The following is a description of a gene set: from publication Yevshin I, Sharipov R, Kolmykov S, Kondrakhin Y, Kolpakov F (PMID 30445619) Human Gene Set: UBN1_TARGET_GENES Genes containing one or more binding sites for (UBN1) in their promoter regions (TSS -1000,+100 bp) as identified by GTRD version 20.06 ChIP-seq harmonization. studied in species Homo sapiens, and this is the list of marker genes: WIZ, GANC, ZNF30-AS1, HMOX2, ZBTB26, TNPO1, FAM217B (family with sequence similarity 217 member B), MIA2, NME1, TANC1, CCDC127, RAPGEF2, LINC02980, PSME2, CKS1B, ZBTB7C, STRC, CENPS-CORT, AHCYL1, POLR1H (NCBI Gene Id 30834), PIBF1, ZNF839, COX5B, CT70, H4C8, DBF4 (NCBI Gene Id 10926), PCBP2, MRPL50, RANBP3L, ZBBX, LNCTSI, KDM1A, PMS2P3, SLC22A4, CARD8, TOP1, ABL1, GFOD1, TMEM91, SMARCC1, PSMD1, NNMT, BCAP29, MIA2-AS1, SLC24A1, CTNNA1-AS1, NREP, PPM1D, SELENOM, HNRNPU, LRRC51, MIR181A2HG, INTS11, USP13, EIF2A, ATXN7L1, CPEB2-DT, VPS35L, ACIN1, TNFRSF19, BASP1-AS1, DNAJC13, ABHD10, NOC3L, UBE2V1, MAP3K7, LHX2, VPS26C, MRPS35-DT (NCBI Gene Id 107984461), PIK3CA, PTK2, GABARAPL1, PPP2R5A, DLST, NOSTRIN, PMS2P4, SARS1, RAI14, ZC3H13, CCT4, RNF212, GOLGA7, COX4I1, B3GALNT2 (beta-1,3-N-acetylgalactosaminyltransferase 2), NIP7, AURKB, CDA, RALGAPA1, LDHA, IVNS1ABP, CARNMT1, LZIC, EHF, C6orf62, KDM2A (NCBI Gene Id 22992), PTDSS1, RIMS1, AP1AR-DT, NPLOC4, NDFIP2, NTAN1, PPP3CB, KRIT1, LINC02958, ANKRD11, PTPN12, ERI2, WDR31, ANO6, SRSF8, ANKIB1, RABGAP1L-DT, KIF2C, RPSA, SUPT16H, ATP5MK, RERE, TTC39C, LMO4, VTA1, RND2, UBB, MRPL55, SYT11, EIF2B4, PANK3, IER2, POLH, BARD1, NUP43, H2AZ1-DT, SNX3, PRC1, TRIM45, GADD45GIP1 (NCBI Gene Id 90480), FTL, MAN1B1-DT, PPP2CB, MATR3, EDEM2, ST7, CARS2, EIF2B5, ANXA11, ASB6, CLIC4, SDSL, SGK1, HSD11B1L, IL6ST-DT, RDH10, XPO5, PPP1R12A, MBIP, COX14, ZNF35, SAR1B (secretion associated Ras related GTPase 1B), MYH9-DT, PTBP1, PSMD14-DT, EPC1, RSPH3, CPEB2 (cytoplasmic polyadenylation element binding protein 2), EEF1A1P23, SYNM, NSA2, PPIP5K2, EPS8, CETN3, GEMIN6, NBPF11, KIAA0930, CD2BP2, DCTPP1, GAREM1, MIR4466, KIAA0825, MICOS13, MSANTD3 (Myb/SANT DNA binding domain containing 3), TRAF4, CMTR2, MED18, CDC25C, YBX3, C1orf43, ZNF112, PHIP, GNG12, NFYC-AS1, NRM, IL18, LINC02615, GPX8, USP33, SHC1, ALG6, RUVBL2, MIR6853, BLOC1S5, ANKRD13D, RRP15, ARID3B, MT1X, RN7SL299P, GGPS1, MYH9, RSRP1, WDR70, LBHD1, NARS2, HCG25, ATG101, H2AC11, SLC27A5, MRPS28 (mitochondrial ribosomal protein S28), SUGT1P4, TBP, SCN9A, GALNT10, SLC38A2, GLS (NCBI Gene Id 51679), VMP1, C6orf47, RNU4-2, P4HA1, G6PD, SPRED1, PPP1R11, CREB3, HIGD1A, ARMH1, DHPS, CYP1B1, ETFBKMT (electron transfer flavoprotein subunit beta lysine methyltransferase), KLHL26, EIF1AX, PCF11, STAMBPL1, GLT8D1, NBPF1, PDLIM7, EPRS1, RASSF1-AS1, KHDRBS1, BSG-AS1, SDE2, LINC01828, SNAPIN, RIPK2, FAM200B, NIPAL3, SBNO2, RNU6-1327P, FOCAD-AS1, DUBR, SNAPC4, SPINK6, MGME1, SNORA16A, IL1RAP, RASSF1, HMGB2, ZNF225, STRAP, SMARCD2, SSB, RNF34, LRRC37A3, FRG1, UBR5, KLRK1, RSBN1, ZNF517, NAA15, BNIP1, PCNX4, THYN1, RN7SL525P, ANXA2, ATL2, MRPS35, CAAP1, DTWD1 (NCBI Gene Id 56986), ZNF787, FAM227B, TRIM4, KHNYN, STAT3 (signal transducer and activator of transcription 3), CCDC88A, RNU6-1276P, DUXAP11, LINC02331, RPS11, UBE2D3-AS1, XYLB, WBP2, DHX38, ADAMTSL4-AS1, OPA1, UPK2, ZNF764, OTUD3, MCTP1, AKIP1, MYLK-AS1, TUBD1, FZD6, RPL27, STAT1, JRKL, SLC30A4-AS1, DROSHA, LINC00881, POLR2K, MIR22HG, CLDN12, GTF2H4, AHCY, NAMPT, SDHA, ZC3H7A, SART1, ADGRG1, SUN1, TRIM5, MAP2K7, TGFBR1, PKM, ZFYVE1, TMEM209, DNAJC3, ABCC3, SKIC8, C12orf60, MIR762HG, ZNF217, MIS18BP1, FAM229B, SIRT1, BTD, AFAP1, GARNL3, CLNS1A, ZBTB17, CLTC, TIPRL, TMEM33, P4HA2, ZMYM6 (NCBI Gene Id 9204), MAN2A2, HECTD1, HMGB1, RDUR, SERINC3 (serine incorporator 3), DNAJC25, HINT1, RAB27A, UBE2R2, ELL, BMF, BICRAL, ENSG00000266401, TNFAIP1, MT1E, SEPSECS-AS1, CXXC5, STAG3L5P-PVRIG2P-PILRB, TMX1, ENSG00000263280, TUBB3, H2BC6, C1QTNF1-AS1, TADA1, NSUN3, ADM-DT, CDKL5, ANP32E, NAGA, TMED7, CCDC82, FHAD1, SCAT8, TXNDC9, LINC02223, MAN1B1, ETV1, ATP6V0A1, PBLD, MAPK4, PITPNM1, FANCM, TLR6, ELMOD2, VPS13B, LRRC27, RNASE11, BRWD3, MRPL33, SYBU, CLIP1, MDC1, VPS13B-DT, PSMA2, MAPK8IP3, VARS2, YIPF3, PA2G4, PLSCR1, RELL1, WDR37, FIRRE, GUSBP1, RB1CC1, SLC38A2-AS1, TGFB1, ATP13A4, H2AC25, RTN2, ZBED6, SLC39A8, IKBKG (inhibitor of nuclear factor kappa B kinase regulatory subunit gamma), LINC01560, RAG1 (NCBI Gene Id 5896), PIK3R3, ZZZ3, CTNNA1, LRRC58, SPTAN1, ZNF862, RNVU1-30, STARD9, CSAD, DNAJC27-AS1, FAM76A, C19orf48P, MAGEF1, LSM5 (LSM5 homolog, U6 small nuclear RNA and mRNA degradation associated), FAM174B, TLN1, AUTS2, KIAA1586, CAV1, TP53BP2, MRPL18, RPS26P29, ANKAR, KIN, PNRC1, SRBD1, SMAD7, COMMD9, ZNF696, SEC24A, AKAP6, PSMA1, GEMIN2, EXOSC6, SIK2, NUMA1, SCN1A-AS1, ZBTB43, FBXO22, KLHL21, USP8 (ubiquitin specific peptidase 8), TCEANC2, RABGAP1L, SH3GLB2, GPC5, MORC3, MRPL45, PCMT1, FEN1, DNAJC25-GNG10, CTSS, PLEKHA3, ZNF548, H2BC10, TNFRSF11B, IL1R1, MYO1G (NCBI Gene Id 64005), THAP1, ATP2C1, MXI1, SRP54, PPIL3, RPS6KB1, POLR1C, ZNF143 (zinc finger protein 143), RACK1, FHIP1A, COX7A2, CHD2, DEPDC1, FUBP1, PDE7B, TAOK2, SNRPA1, SMARCD1, ZNF527, ZNF451, PEX3, H2BC11, TRAJ28, TMEM258, SF3A3, PDK4-AS1, PAK1, RNF168, TXNL4B, GALM, AP3B1, TRIM28, DPAGT1 (NCBI Gene Id 1799), ILF2, CD46, TMED7-TICAM2, HYKK, GAB1, HOXC-AS3, USP3-AS1, GON4L, ACTN3, SNORD104, SINHCAF, PCNX4-DT, ZNF250, ACOT13, LARP1B, IGFBP7, THOC5, DBNL, SAMD4B, PFN1, COG8, NUDT3, ALDH7A1, KCTD3, RAB5B, TMEM263, DENND2B, TOMM34, DAPP1, NDFIP2-AS1, WNT5A, MYORG, CREB3L2-AS1, PARAIL, BAG1, ASB3, CCNH, RPA3, CEP152, GBA1, CISD3, FAS, PGP, MIR759, ZNF225-AS1 (NCBI Gene Id 100379224), SNORD12C, MRPL1, ADAT2, TBC1D23, NICN1, TUSC1, UHRF2, HSPB3, EXD3, SKP1, TFB1M, DDX60L, LINC01686, ZFAND6, POLR1HASP, DLEU2, DPH5, NCAPD2, ZNF131, SPG21, CPSF1, AMN1, LINC00677, NKIRAS1, EPHA7, TNC, CDC37L1, ALPK2, FEM1B, YIPF5, RBMS3-AS3, RCOR3, IFRD1, DLGAP1-AS2, RPL23A, DLD, ZDHHC24, THBS1, NFATC3, UBE2G1, AFG2A, C14orf119, RPL4P6, TMEM30A, KCNMB2, MAP1LC3B2, CNPY3, FADS1, MRPS24, YAE1, HSPB8, PYM1, UBAP2L, UFL1-AS1, ENSG00000257732, LINC01108, ZNF785, RDX, RABEPK, TIPIN, NDUFC1, LINC00111, SPDL1, ACAA1, SLMAP, FAM13A, HAUS2, TMEM68, TTC23, OBI1 (NCBI Gene Id 86572), CSTBP1, PSMD14, BBS7-DT, SLC25A36, TOP6BL, SLC25A25, TEAD4, MIRLET7BHG, MIR4519, ANO3, ACLY, ZBTB25, H4C3, SSH2, CSRNP2, RNF20, RAD52, ENSG00000260830, MAT2B, NDUFV2, BCL7B, ZNF780A, PDCD6-DT, ADAMTS3, EEF2K, CCNYL1, EMC4, DHTKD1 (dehydrogenase E1 and transketolase domain containing 1), ISL1-DT, TSEN34, DENND6A-DT, DCBLD2, LRRC40, MIR99AHG, DLGAP1-AS1, TFAP2A, NCBP1, DUSP19, COX16, ZSWIM9, ARRDC3, CPE, RPL15, LRIG3-DT, NFKBIA, LAPTM4A, CUL7, CHMP7, RASGRP3, TOX4, MPLKIP, TRMT11, LNCRNA-IUR, MITD1, SH3RF2, AVPI1, BRAF, CASC3, REEP3, TOM1L2, INPP5F, ANO10, GAR1, ARL6IP5, RN7SL346P, SRGAP1, SPAG5-AS1, GPT2, ZNFX1, RBM26-AS1, PLAUR, LINC02918, AQP5, TGDS, ODAD4, ZNF575, TAPT1-AS1, B4GAT1, IFT25 (intraflagellar transport 25), PRKCE, SH3BGRL, FAM174A, TMEM106B, SEMA3C, TMEM50A, ATP5MC2, CCDC190, SNORD68, RNU6-554P, KCNJ2-AS1, FBXO33, LINC00265, DENND4A, CEP44, ELMOD3, CBLN3, ITPR1, HSD17B11, HSPA2, RRS1, RPL13, FST, SLC25A5, MRPL44, NUP153, HOXC10, SLC25A40, NIPSNAP2, SETDB2, PLAGL1, PIK3CA-DT, LIPA, CXCL8, SDC2, NEDD4 (NCBI Gene Id 4734), RRP9, ZNF503-AS1, PPFIBP1, GSPT1, RAB13 (NCBI Gene Id 89672), TOMM5, SPECC1, ITGA3, TUBE1, MPC2, SCYL3, H1-4 (NCBI Gene Id 3008), MIPEP, ZNF45, EPHX1, NBN, RPA2, LINC01122, CRTC3-AS1, C1S, BTK, CP, GPATCH4, OSGEPL1, MT2A, LINC02274, SLC16A1, RBMS1, NME1-NME2, HES1, ARID2, HIGD2B, C14orf93, TAB1, KNSTRN, MIR4258, TPM2, ZFAS1, F3, DDX47, LMBR1L, PAX6, ORC5, CEP350, HBP1, INTU (NCBI Gene Id 27152), CT83, JPH2, ACACA, SMIM14, SAP30-DT, RBM45, PDE12, GFM1, MRPL30, CCDC25 (NCBI Gene Id 55246), PHF14, CPEB4, KMT5A, SMNDC1, DST, CAMTA1, UGCG, PDE4B, METTL8, RNU6-92P, BSDC1, S100PBP, POLR3E, GTF3C3, ARHGAP5, SLC39A13, CASC11, PNRC1-DT, PSMC6, EMSY-DT, C2orf42, LUC7L2, TAF1B, CAB39L, STAG3L3, CASC2, MTMR2, GLB1, FAF2, GNB2, RNVU1-21 (NCBI Gene Id 106480190), PHACTR4, SLC2A13, B9D1, FHIP1A-DT, MAPK7, IPO13, IQGAP1, TP53RK, BAZ2A, AQR, HAUS3, WFDC21P, SIK3, HINT2, GDF5, ZNF117, ANXA8, LOX (NCBI Gene Id 4015), PRELID3BP5, MCC, KLRC2, DNAJC7, PIP4K2B, STX10, SNORA50C, MYL6B, CENPU, PPP1R3D, PSMD5, SMPDL3A, RBBP6, GSR, PPM1N, SLC7A11, TOB1-AS1, HSPA4L, XPC, LINC02912, CEP128, TNRC18, TMPPE, FOXO6, ZNF697, VAC14, ST7-OT4, ALDH1B1, ANAPC16, PPP3CB-AS1, RPS19BP1, TLR1, ENSG00000229425, MFF-DT, RAET1E-AS1, IDH1, AKNAD1, SIL1, C11orf91, ADCK5, B4GAT1-DT, USP43, C6orf89, EFNA4, PRECSIT, FMC1-LUC7L2, PGAP4, ECI1, ALG10, DRC3, RERGL, ZNF266, TCERG1, SOS1, NPR3, EEF1B2, TOB2, SNX7, PPIL1, UBXN7, MNT, CLK4, PTPA, YWHAZ, EIF4E2, SSBP1, EVPLL, ESRRA, MRPL16, FAM86FP, UBR5-DT (UBR5 divergent transcript), RNU7-11P, GORASP2, PAICS, FOSL1, SETD9, POLR1B, FRG1CP, ZNF41, GLI3, CCDC9, PRRT3-AS1, EYA4, FRG1-DT, KIF27, PTP4A2, TMEM41B, AQP5-AS1, HACL1, PPIC, DHFR2, CASP8, GEMIN5, BBS4, RNF135 (ring finger protein 135), TXNDC8, ZBTB20, RXFP1, FMC1, KCNJ2, TLN2, EPB41L2, LRRC8D, SNTB2, ST7L, CDC25A, MEGF9, PMEL, TDG, YOD1, VRK2, ARPC1A, TYW5, ENO3, FBXO38, POLD1, SUGT1P4-STRA6LP, RBBP5, THAP3, ZNF335, CTR9, EPDR1, VTRNA1-2, AHCYL2, STIM2, TIGD1, CRADD, RAB10, CDC42EP4, CKS2, SF3B4, BLOC1S6, FNBP4, PRIM2, TSPAN12, PARP3, NCOA3, EGR2, ENSG00000249236 (NCBI Gene Id 105378976), DGKA, PUM3, CDK5RAP2, TAF9B, ROBO1, CNPPD1, ACKR2, BTBD3, LRRC37A5P, C18orf32, SNX7-DT, MAP2K5, HNRNPF, ERC1, NANS, VAPB, CSRP1-AS1, TM2D2, HPD, TMEM19, PPP4R1, SPTBN1, CDC37L1-DT, GDF9, SLPI, ZNF184, PAM, MFF, ZMYND10-AS1, ENSG00000253397, HIP1R, ACTR1B, SAR1A, UGGT1, PRPF19-DT, DUSP23, BAALC-AS1, IGF2BP3, MYO10, FADS2, FBXL3, SCNM1, KGD4, MYBL1, POLA1, STARD6, USPL1, ENO1, RETSAT, ADAMTS6, GAS1RR, CCAR1, ZFP37, RAB34, PLEKHA8P1, LSG1, RAPH1, ATP6V1F, MVB12A, RNU6-1, SRD5A3 (steroid 5 alpha-reductase 3), ATP6V0D1, LINC01409, NOL6, DIO2, PLTP, LINC01091, STPG1, WWP1-AS1, CCDC7, SESN1, PALLD-AS1, TOB1, MGRN1, CCDC159, PRPF3, IFT20, ADSL, LINC03108, KCMF1, SEMA4F, BBS12, ECPAS, ARHGAP28, CLCF1, SERAC1, RPS9, FBXO38-DT, HCCS, YARS1, AK5, TSPAN17, CAMK2D, ZNF286A-TBC1D26, DTD1, DKKL1 (NCBI Gene Id 27120), SPAG5, NAXD-AS1 (NAXD antisense RNA 1), LSM2, CRB1, CD2BP2-DT, SMIM14-DT, PAGR1, SSBL4P, PRKAG2, MAN1A1, SEPSECS, LRRC57, MEOX1, SYNC, NUP50, DEDD, LAPTM4A-DT, NUDT6, FGD4, QRICH1, RBMS3, DHRS4-AS1, RPRD1B (NCBI Gene Id 58537), LAMB1, COX6A1, AGTRAP, RPL36A, RAB2B, GABRE, MGC32805, ARGLU1, NOD1, COPS4, TNKS2-DT, NWD1, RSRC1, NUP107-DT, RTN4, NMT1, CACNA2D1, GALNT7, ADM, KLHDC10, SRP54-AS1, CAP1, ESYT2 (extended synaptotagmin 2), PITPNC1 (NCBI Gene Id 731962), NFATC4, AK2, SMC5, TGS1, SFI1, AGPAT4, ADAM9, LAMA4, METTL2B, SCAND3, GLT8D2, IDH1-AS1, THADA, LINC01960, GPR89B, ZNF668, HECW1, GADD45A, PIGS (NCBI Gene Id 94005), C5orf15, TSTD2, LIG1, UQCC6, RAD51, MYBBP1A, CDKN2B, BTRC, BTNL12P, ALDH3A1, FOXC1, ZMYM5, SLC9B1 (NCBI Gene Id 150159), BSG, CREB5, CDKN2D, STX16-NPEPL1, RNF31, PCDHAC2, TFCP2, BZW1, KIFAP3, DHX16, DNAJC21, RRM2B, LINC01010, COL3A1, VXN, GULP1, CASTOR1, CAPZA2, SLC38A9, EIF4ENIF1, C1orf122, DYNLL1, ATF7IP, NIF3L1, PHF21A, SLC26A2, UGDH-AS1, DHX8, ACAP2, FASN, SHOC2, SECISBP2L, RAB30-DT, SLC16A1-AS1 (SLC16A1 antisense RNA 1), ANKRD18B, SLC33A1, RPS15A, ZNF436, VPS45, SYT12, GPR141 (G protein-coupled receptor 141), WDR47, PDLIM5, ZNF892, MIR100HG, TRAJ27, IQCN, SNHG31, LINC02777, UGDH, KLC2-AS2, HTR1D, ARPC5 (actin related protein 2/3 complex subunit 5), CA5B, NCAPG2, VIM-AS1, PSAT1, WRNIP1, BLOC1S5-TXNDC5, PDCD6, EIF2AK4, IPPK, ANKRD46, IL17RA, NSUN4, MIPOL1, SPATA1, EBF1 (NCBI Gene Id 1879), ITGA1 (integrin subunit alpha 1, NCBI Gene Id 3672), EEF2KMT (NCBI Gene Id 196483), LINC02608, PGAM1, EPS15L1, VPS28, ZNHIT2, CHD1L, MIR4470, ADNP (activity dependent neuroprotector homeobox), SND1, RGL1, FBXO46, ZNF282, L3HYPDH, HSPA1B, BBS7, AKR1D1, CEP250, PLCD4, ATG5, HACD2, SCAF11, FBXL5, LINC01014, MND1 (NCBI Gene Id 84057), EYS, POLN, ATG4C (NCBI Gene Id 84938), PCLO, BTN3A2, SIKE1, CEP72-DT, C18orf54, TAF11, PMVK, GGCTP1, FAM174A-DT, TAPT1, GOT2, NSMCE4A, MIR4500HG (NCBI Gene Id 642345), ZNF646, EED, PALMD, DYNLRB1, ZNF252P-AS1, DNAJC12, RAB30, HMGN4 (NCBI Gene Id 10473, high mobility group nucleosomal binding domain 4), PLA2G12A, POLDIP3, OLA1, RAB1B, MAN2A1, CNTRL, NUP58, ATIC, RC3H2, ZCCHC24, KCTD16, GBA1LP, TPX2, PRDX1, DNAJC3-DT, ASPSCR1, TSKU (NCBI Gene Id 25987), LINC01623, MBOAT7, S100A10, PARS2, BICD1-AS1, CHCHD3, SYMPK, SPCS1, MED21, EMP1, APOO, SEMA3D, ACTR1A, RAC1, DAXX, ENSG00000260288, C19orf33, ENAH, ZNF740, TAF1D, TIMM10, HES7, GPRASP3P1, RPS3A, MAIP1, INTS14, SNHG25, STAG3L5P, YTHDF2, HELLPAR, HCG20, ATG9A, ZNF770, TSPAN8, COTL1, TAF10, SMIM26, STARD3NL, RRP12, POLG, COL12A1, PFAS, FOXA3, LINC00513, ENSG00000248161, RNU5B-1, MSTO1, ZNF34, ZNF286A, ZC3H10, NCOA7, CEP112, SPICE1, CAPN10, PSMA6, TRAF6, CHAC2, TMEM59, SLC38A4-AS1, CSRP1, LRP12, ANG, TUBA1B-AS1, TRIM3, SS18, RPL11, GPR37, WASL, NDUFAF1, MED4, RYK, ID3, FLNC-AS1 (FLNC antisense RNA 1), TBL1X, TRNAU1AP, GTPBP3, NMNAT1, TRIM2, NFIA, DNAJC6, CUL3, ACTA2, LYSMD1, SEC11A, GSTM3, CMTR1, VAV3, IFI6, VIM, ZNF143-AS1, IFT57, ZYG11A, COA6, PLEKHF2, ASCC1, MIDEAS, SLC6A6 (NCBI Gene Id 6533), DPH6, SBF2, PHF3, PSMG1, ARHGEF39, MAPK14, ESRP2, JUNB, RSL24D1, EPHA2-AS1 (EPHA2 antisense RNA 1), TOMM22, SMIM2-AS1, CYB5B (cytochrome b5 type B), PRRG1, AMOTL1, TPRKB, DHFR, CDK11A, GAR1-DT, DUSP12, PAX8-AS1, APEH, DCP1A, FKBP3, GNPAT, NAA40, RBAK, FALEC, MTERF3, CCDC80, SNX17, CRKL, BCAN-AS2, CMAHP, RFFL, LINC01910, TGIF1, SUMO2, SNHG12, GPNMB, STC2, SPAG4, S100A11, WBP1L, SIPA1, TOMM22-DT, NF2 (NF2, moesin-ezrin-radixin like (MERLIN) tumor suppressor), ACAD8, HMGN5, PLPP1, S100A2 (S100 calcium binding protein A2), ERV3-1 (NCBI Gene Id 2086), DERA, TRIM69, RBFOX2, LINC00882, TNFAIP2, H2BC20P, NOLC1, LAMA2, UTP3, TTI2, COMMD6 (COMM domain containing 6), IMMT, GYS1, RIGI, G3BP2, CEACAM16-AS1, GNPTAB, GRAMD1B, UQCC1, ABCA8, POC1A, MAD1L1, C12orf57, GMPS, STX16, CREB3L2, STAG3L4, LINC02202, HCCS-DT, DPH5-DT, CALD1, JAK2, RARA, C2orf92, GSN, ARHGAP18, LIG4, FAM161A (NCBI Gene Id 84140), SND1-DT, ATP5PO, RPL36A-HNRNPH2, SP4, MGP (matrix Gla protein), DESI2 (NCBI Gene Id 51029), EIF5B, SH2D6, OSGEPL1-AS1, CCNG1, LINC00649, DNTTIP2, BBIP1, P3H1, PNRC2, GPR137, ADPRHL1, SUGT1P4-STRA6LP-CCDC180, ARID4B, ANKRD49, CCP110, CACNA2D4 (calcium voltage-gated channel auxiliary subunit alpha2delta 4), DRG1, PFKFB2, CREM, S100A4, TOR4A, PPP3R1, PLOD2, CFAP54, LINC02265, MCUB, PICART1, MIR5087, TMEM126A, CREBZF, C1orf50, NFIB, ERGIC2, STAM, LINC01714, ASF1A, DPH6-DT, JAZF1, PSMB1, MTAP, LINC02888, FRS2, DDX24, TXNIP, DDB2, YTHDF1 (NCBI Gene Id 54915), TRIM47, ADIPOR2, OSBP2, RN7SL408P, MBD2, LYRM7, MYL6, WEE2-AS1, LAMB3, GLP2R, DCUN1D3, OGG1, CHD9, ABALON, INTS2, SH2D3C, INTS4, RPS6KA1, CCDC12, RNVU1-4, RBM22, UBE2D3, NCOA1, PHF19, CLU, CENPS (centromere protein S), SNX5, RPS13, TTC39B, ELOVL5, ATP6V0D1-DT, ZNF223, CYP51A1-AS1, ATP2B1, PRP4K, ANKRD28, TXNP5, GABARAPL1-AS1 (GABARAPL1 antisense RNA 1), KDM3A, SMC2, ARL17A, RIF1, CLUH, USO1, RELCH, TP53RK-DT, DMAC2L, PTPN14, TSPAN1, DHX37, SNRPA1-DT, DLEU1, LSM4, MBP, TCP1, PSMC1, TUBA1A, PDE4D, COMMD1, TMEM47, CPEB3, IGFBP5, ADSS2, SRD5A1, ERCC1, TYSND1, PKN2, CAPRIN2 (caprin family member 2), RNF145, MRPL51, ZNF189, NVL, HNRNPUL1, GLRX, SERP1, LINC02226, RNASE4, TMTC2, RIOK2, FARS2 (NCBI Gene Id 10667), RNY3, ANKZF1, YTHDC2, ZNF30, PPP1R12C, RPL37, PCID2, TMF1, MFAP3, CD82, CLCN3, IL6ST, BLTP3B-DT, ZNF252P, EMC8, GALK2, SLC2A4RG, RINT1, RPL7, GRIP1, NAMPT-AS1, ZC3H11A, CAPZA1, IPP, BIRC6, PEX6, MALT1 (NCBI Gene Id 10892), ZFP36L1, KDM4C, NSUN2, TSKU-AS1, MTMR9, PLOD1, JKAMP, CT66, IMPA2, PLCE1, SLC44A1, SRSF9, PARD6G-AS1, DDX41, GFM2, STAG2, TDRD3, SETD5, DIS3, AHNAK, YLPM1, ITPR1-DT, FNDC3A, UBE2K, ASPH, CAT (NCBI Gene Id 847), AP1AR, UMAD1, FHIP1B, CBLB, ZCCHC8, SLC25A5-AS1, CACNB3, GPSM2, SEC22B, TRMT44, LRIG3, WDR25, TLR4, CDC27, ADAT1, POLG-DT, ESYT1, H4C5, HERC4, ATOSB, GIN1, MED17, SLC2A1, LINC03033, H3-3B, TUT1, EFNA4-EFNA3, TNFRSF1A, GTF2H5, UQCRQ, MCM9, LINC02098, MSH3, MARCHF5, SHROOM3, PRPF19, SCP2, NRP1, BRF2, AGGF1 (NCBI Gene Id 55109), TADA2A, PRDM1, BCL9, LYRM1, SRSF7, ANAPC5, SESN3, ATP6V1H, NMRAL1 (NCBI Gene Id 57407), SPRYD7, SLC1A5, SMC2-DT, RICTOR (NCBI Gene Id 253260), ENSG00000228395, TUBA1B, ZNF280C, RRS1-DT, MAN2A1-DT, RALY, CALCOCO1, FAM114A2, BAX, FIBIN, TBCC, HPF1, IFI27L1, ZC3H3, YAE1-DT, TBC1D4, MYL12B, NUP50-DT, MAPK1IP1L (mitogen-activated protein kinase 1 interacting protein 1 like), NABP2, CEP57L1, MDN1, STK40, MAP4, PTRH2, RAB6A, ABT1, ENSG00000255647, LTBP1, ABHD13, CALCRL-AS1, FAM53C, PDCD11, SS18L2, RAD51-AS1, SRSF4, E2F2, TMEM87A, NKAPP1, BRAT1, CPB2-AS1, RAB3A, STON2, RBAK-RBAKDN, MIR4425, C5orf22, BLM, LIFR, MKRN2, PUM2, MRPL45P2, TDP2, NFE2L2, LRRC42, SEC22C, VKORC1, H2AC10P, TMEM177, CETN4P, CHMP5, GCFC2, ZC3HC1, UQCRBP2, FAM193A, RPL36, EMSY (EMSY transcriptional repressor, BRCA2 interacting), GIPC2, ANK3, TGM2, TIMP3, EIF2D, SMAD5, FBXO47, CDHR3, NUP35, PWWP2A, DNAJB4, ENSG00000267248, RASA1 (RAS p21 protein activator 1), FAAP20, NEK4, SUGCT, TRD-AS1, SAP30, MACF1, NOXA1, ZNF81, MIR4458HG, EIF3H, CLASP1, COPB1, ANXA1, DRAIC, MPDZ, PROCA1, BCL2L13, ARL4A, ARB2A, NUP107, HADHB, MLF2, POLR2D, C2CD5, RETREG2, TES